Given this list of marker genes Dock7, Ranbp10, Rac1, Rps27a, Fn1, Rap1a, Lama4, Grb2, Ptprj, Kras, Lrig1, Met, Col3a1, Itga2, Crk, Pik3r1, Col5a2, Col1a1, Col11a1, Col11a2, Src, Ptpn2, Sh3gl2, Shc1, Rab4a, Crkl, Col5a3, Rab4b, Uba52, Megf6, Spint1, Itga3, Ptpn1, Col2a1, Usp8, Hgs, Sos1, Ptk2, Hgfac, Gga3, Col1a2, Hgf, Muc20, Spint2, Uba52rt, Ptpn11, Col5a1, Sh3gl3, Gab1, Arf6, Stam, Tns3, Tns4, Eps15, Hras, Cbl, Stam2, Ubb, Pik3ca, Hpn, Rapgef1, Stat3, Itgb1, Sh3kbp1, Rap1b, Ranbp9 (RAN binding protein 9), Sh3gl1, Ubc, here is a description of the gene set: Signaling by MET studied in species Mus musculus Mouse Gene Set: REACTOME_SIGNALING_BY_MET